The following is a description of a gene set: Abnormality of the growth of the axillary hair. Axillary hair is part of the secondary sexual hair, which normally ensues during puberty. species: Homo sapiens Abnormality of the axillary hair Human Gene Set: HP_ABNORMALITY_OF_THE_AXILLARY_HAIR, and this is the list of marker genes: LHB, SRA1, CCBE1, DSC3, ZBTB20, RPL21, HLA-DRA, MAP3K1, LSS, SPRY4, WT1, TBX3, APCDD1, WWOX, FSHB, NR5A1, GNRH1, LPAR6 (NCBI Gene Id 10161), GJB6, ADAMTS3, GATA4 (GATA binding protein 4), KRT74, CYP17A1, AXIN2, COL17A1, APOE, VAMP7, WDR11, GNRHR, FEZF1, SEMA3E, FGF17, FAT4, TP63, NR0B1, SNRPE, SOX9, CYB5A, ITGB4, CCDC141, HR, KCTD1, PSMB8, PPP2R3C (NCBI Gene Id 55012), ZFPM2, AR, DHX37, SRY, ORC6, EPS8L3, LIPH (lipase H), AXL, CDSN, DUSP6, GJB2